The following is a description of a gene set: studied in species Homo sapiens Reactome Pathway: NFE2L2 regulating anti-oxidant/detoxification enzymes Subpathway representing cytoprotective genes regulated by NFE2L2 (NRF2). NFE2L2 is well-studied for its role in oxidative stress where it gets activated by ROS and then induces a plethora of gene expression regulation the oxidative damage. It induces genes/enzymes that regulate the phase 2 detoxification system (eg. GSTs and Glutathione system), ROS scavenging (SODs,PRDX1 ) and cytoprotection (HO1) by regulating inflammation and tissue damage part of: Nuclear events mediated by NFE2L2, and this is the list of marker genes: TXN, CHD6, SLC7A11, SOD3 (superoxide dismutase 3), TXNRD1, GSR, EP300, PRDX1, GCLC (NCBI Gene Id 2729), GSTA1, SRXN1, ATF4, MAFK, GCLM (glutamate-cysteine ligase modifier subunit), NQO1, BACH1, GSTA3, CREBBP, HMOX1, NFE2L2